The following is a description of a gene set: Genes down-regulated in comparison of neutrophils versusl monocytes. Immune cell-specific expression is one indication of the importance of a gene's role in the immune response. In order to identify such patterns, we set out to broadly profile gene expression in a variety of immune cells. Human Gene Set: GSE22886_NEUTROPHIL_VS_MONOCYTE_DN studied in species Homo sapiens from publication Abbas AR, Baldwin D, Ma Y, Ouyang W, Gurney A, Martin F, Fong S, van Lookeren Campagne M, Godowski P, Williams PM, Chan AC, Clark HF (PMID 15789058), and this is the list of marker genes: RPS7, IRF8, NDUFS1, NDUFAB1, TOMM20, IL10RA, RPL26, SRSF7, AQR, GNPAT, TIMM17A, TIMM13, PDHA1 (pyruvate dehydrogenase E1 subunit alpha 1), SLC16A7, SHLD2, GNS, SLC27A3, EXT1, NONO, AHNAK, CYC1, RPL23, EIF3A, HNRNPA2B1, SSR4, NUP85, NRIP1, HSP90AB1, UQCRC1, UROD, NIPSNAP2, USP24, PSMD3, DDX39A, TMSB10 (NCBI Gene Id 9168), PEA15, NARS1, MGST3, RTRAF, TRA2B, NDUFA9, MRPS7, VDAC2, CUL5, CYBB, CTSB, SFPQ, NAXD, GNL2, YTHDC2, NUP62, FBXL14, SEC31A (SEC31 homolog A, COPII coat complex component), NAP1L1, DRG1, RPS24, PTPN2, PSMC5, UFC1, HLA-DPA1, HLA-DRA, EOLA1, NPLOC4, DNM1L, CREB3L2, LGALS1, EIF2B1, OPN3, ATP5MC3, DDX1, AUP1, COMMD3, NAA15 (NCBI Gene Id 80155), MAFB, AIMP1, PDXDC1, IDH3B, RTCB, ATP5PO, ESD, GUSB, NAGPA, GSTP1, VCAN, SRSF3, ENO1, DHX15, GPX1, NDUFS6, PRMT1, UTP18, EIF3M, SEC63, PSMA1, DPYD, CLSTN1, RPS25, PIH1D1, EIF3D, XPO1, MCUB, LRRC8D, CERS6, HNRNPD, STRAP, RIN2, PPRC1, CCT8, IMP4, TNS3, LGALS3, UCP2, UTP3, MRPL57, SNRPF, EIF4G1, TMEM147 (transmembrane protein 147), ATP5F1B, CANX, NDUFS4, RPS20, BANF1, SMIM10L1, FASTKD1, IRAK3, MDFIC, KLF10, KARS1, COX5A, SLC7A7, DUSP3, PLXNB2, MTIF2, AKR1A1, GSAP, RNH1, EPRS1, NDUFA4, SUPT7L, POLR2L, CCT3, SLC25A3, CTSH, IMMT, TPP1, YBX1, MTO1, CCT4, RPL11, FBP1, UQCRH (NCBI Gene Id 7388), CD44, SYNCRIP, RPS27, RECQL, PARK7, LGALS8, TTC3, RBM3, HSD17B4, ADH5, RPS13 (NCBI Gene Id 6207), NMT1, RPS27A, MAT2A, RPL37, WDR11 (WD repeat domain 11), RACK1, ZNF706, SMC5, KTN1, RPL9, METTL9, EIF4A1, RABGGTB, RAN, MRPL3, SUMO3, CAPN2, DNMT1, SNRPD3 (small nuclear ribonucleoprotein D3 polypeptide), KLF4, SGSH, PWP1, TRAPPC2L, MRPS35, EIF3L, NUBP1, ANXA2, GRPEL1, HEXA, YARS1 (tyrosyl-tRNA synthetase 1), ACOT9 (acyl-CoA thioesterase 9), S100A10, RUVBL2, PLOD3, ANXA2P2, KCTD12 (potassium channel tetramerization domain containing 12), SKIC3